Given this list of marker genes MIR3140, ANAPC10, MND1, LINC02432, RPL31P26, TTC29, HHIP, RAB33B, LINC02355, RN7SKP237, AKIRIN2P1, ENSG00000305695, MAB21L2, SETD7, C4orf51, RPS3A, RNU6-1282P, NMNAT1P4, LINC02276, RNA5SP167, ENSG00000308479 (NCBI Gene Id 124900788, novel transcript, antisense to INPP4B), RNU6-1230P, MGST2, ABCE1, SMAD1-AS1, ARHGAP10, MIR4799, RNU6-506P, SMARCA5, TNRC18P1, ENSG00000250406, GUSBP5, ARFIP1, RNY1P14, RN7SL311P, POU4F2, ASS1P8, ENSG00000270681, ENSG00000286896, LINC03074, LINC01095, RNU7-197P, RPS3AP18 (RPS3A pseudogene 18), MMAA, USP38, RTN3P1, FTH1P24, RNF175 (ring finger protein 175), FBXW7-AS1, MGAT4D, ZNF330, RNA5SP165, MIR3139, GYPA, REELD1, NAA15, NSA2P6, UCP1, TMEM184C-DT, RNU6-1196P, SNORD73B, TMEM154, SH3D19, AK4P6, RAB33B-AS1, PRMT5P1, DCLK2, IL15, RPS23P4, INPP4B, RNA5SP168 (RNA, 5S ribosomal pseudogene 168), NCOA4P3, GTF2F2P1, ENSG00000249690, LSM6, GYPB, RNU6-531P, RN7SL446P, NR3C2, ZBTB8OSP1 (NCBI Gene Id 730921), TBC1D9, DCHS2, CLGN, PLRG1, MIR548G, WDR77P1, TRIM2, RN7SL152P, RNA5SP166, ELF2, FHIP1A-DT, LINC02266 (NCBI Gene Id 105377466), SCOC-AS1, RN7SKP35, MAML3, FGA, TMEM184C (NCBI Gene Id 55751), SMARCA5-AS1, NDUFC1, OTUD4, RN7SL254P, H3P16, LSM3P4, RPL5P13, ANXA2P1, SMAD1-AS2, FGB, LINC02273, WDR45P1, QKILA, RN7SL382P, TMEM131L, FHDC1, RNU6-1285P, MIR7849, HHIP-AS1, FHIP1A, LINC02430, ATP5MGP4, LINC02507, USP38-DT (USP38 divergent transcript), ENSG00000248335, KRT18P51, ENSG00000290441, MIR4453HG, HSPD1P5, RNF150, RNU7-194P, SFRP2, PPP1R14BP3, RN7SL419P, SLC10A7 (solute carrier family 10 member 7), FBXW7, RNU6-1074P, MIR4453, SMAD1, GATB, ZNF827, RN7SKP235, FREM3, RNU1-44P, RNU6-1214P, ENSG00000239005, PRMT9, ENSG00000249818, NOCT, PRSS48, TLR2, RN7SKP253, EDNRA, RPSAP36, SCOC, RPL14P3, GAB1, GYPE, IQCM, MGARP, FAM192BP, RNA5SP169, NDUFB4P9, TIGD4, SNORD73A, ELMOD2, LRBA, here is a description of the gene set: Human Gene Set: chr4q31 studied in species Homo sapiens